The following is a description of a gene set: The attachment of an epithelial cell to another epithelial cell via adhesion molecules. studied in species Mus musculus Mouse Gene Set: GOBP_EPITHELIAL_CELL_CELL_ADHESION, and this is the list of marker genes: Ctnna1, Bves, Kifc3, Dsp, Plekha7, Kit, Camsap3, Srf, Ihh, Itgb5, Ccn3, Svep1, Pkp3, Serpinb8, Cyp1b1, Thbs4, Vcl